Given this list of marker genes HERPUD1, NETO2, CYP2F1, TBC1D9, CFHR1, MT2A, SFXN1, KYNU, IGF2, TBC1D8, TDO2, DPYD, ELOVL5, ZC2HC1C, MEOX2, PFKFB1, AASS, ABCC10, ORM2, CFH, RGS16, RIDA, PCOLCE, HAL, ORM1, HAO1, PNLIPRP1, AQP8, C4BPA, HSPA5, DMBT1, PCK1, DCT, MAPKAPK2, FKBP5 (NCBI Gene Id 2289), OTC, PNLIP, EFEMP1, CTRC, EGFR, ZG16, RARRES1, G6PC1, RBFA, FGG, ELANE, MTARC1 (mitochondrial amidoxime reducing component 1), POGZ, SERPINA3, KLF15, REG1A, HSPH1 (heat shock protein family H (Hsp110) member 1), IGF1 (NCBI Gene Id 3479), TCIM (transcriptional and immune response regulator), SLC37A4, HBP1, IL1R1, KLK5, BHMT, SATB1, IGFBP2, G0S2, GOT1, here is a description of the gene set: Genes down-regulated in hepatocellular carcinoma (HCC) induced by overexpression of MYC. from publication Lee JS, Chu IS, Mikaelyan A, Calvisi DF, Heo J, Reddy JK, Thorgeirsson SS (PMID 15565109) Human Gene Set: LEE_LIVER_CANCER_MYC_DN Genetically modified mice have been extensively used for analyzing the molecular events that occur during tumor development. In many, if not all, cases, however, it is uncertain to what extent the mouse models reproduce features observed in the corresponding human conditions. This is due largely to lack of precise methods for direct and comprehensive comparison at the molecular level of the mouse and human tumors. Here we use global gene expression patterns of 68 hepatocellular carcinomas (HCCs) from seven different mouse models and 91 human HCCs from predefined subclasses to obtain direct comparison of the molecular features of mouse and human HCCs. Gene expression patterns in HCCs from Myc, E2f1 and Myc E2f1 transgenic mice were most similar to those of the better survival group of human HCCs, whereas the expression patterns in HCCs from Myc Tgfa transgenic mice and in diethylnitrosamine-induced mouse HCCs were most similar to those of the poorer survival group of human HCCs. Gene expression patterns in HCCs from Acox1(-/-) mice and in ciprofibrate-induced HCCs were least similar to those observed in human HCCs. We conclude that our approach can effectively identify appropriate mouse models to study human cancers. species: Homo sapiens